Given this list of marker genes TGIF1 (TGFB induced factor homeobox 1), SMC1A, CNOT1, STAG2, PTCH1, FGFR1, FILIP1, SEC31A, ZIC2, SIX3, here is a description of the gene set: A type of holoprosencephaly in which the left and right frontal and parietal lobes are fused and the interhemispheric fissure is only present posteriorly. studied in species Homo sapiens Human Gene Set: HP_SEMILOBAR_HOLOPROSENCEPHALY Semilobar holoprosencephaly